The following is a description of a gene set: from publication Chen Y, Wang X (PMID 31504780) Genes predicted to be targets of miRBase v22 microRNA hsa-miR-526b-3p in miRDB v6.0 with MirTarget v4 prediction scores > 80 (high confidence targets). Human Gene Set: MIR526B_3P studied in species Homo sapiens, and this is the list of marker genes: PRR14L, CLIP4, OSTM1, LRPAP1, ZNF280B, ZNF264, RORC, FBXL3 (NCBI Gene Id 26224), PKD2, PLEKHA3, ARHGEF3, USP32, VSX1, BRMS1L, PCDHA12, MOSMO, CALD1, CCDC71L (coiled-coil domain containing 71 like), PTHLH, USP3, ZNFX1, DENND10, NIPA1, TMEM167A, KLF11 (NCBI Gene Id 8462), RRM2, ZBTB9, PPP1R15B, RLIM, ERAP1, HBP1, BAHD1, ENTPD4, RAB5B, RBBP7, DNAJC27, ETV1, SSX2IP, SRCIN1, RCCD1, PTPN4, FGD4, SLC45A4, BTBD10, BCL11B, CEP170, MKNK2, EPHA4, RAB22A, ARMC8, ZBTB20, KLHL28, PCDHA2, PURB, MKRN1, MAGI3, RAB8B, APP (NCBI Gene Id 351), ULK1, SLC24A2, PTPDC1, GOSR1, TMEM127, ANKRD52, RASGRF2, ZNF25, OTUD4, SMOC1, STXBP5, FAM13C, SPTY2D1, SMOC2, KIAA0513, RGMB, EGLN3, SLC40A1, DDX5 (DEAD-box helicase 5), TBC1D20, TET3, MASTL, LASP1, USP6, ARHGEF11, MMP2, TGFBR2, FSD1L, REV3L, CDC23, DNAJC16, FBXL5, KIF3B, IQSEC2, CORO2B, LDLRAP1, TRDN, NPAS3, STRIP2, AGFG1, BRWD1, PFKP, SOS1, ZNF148, EREG, SUCO, VLDLR, ZBTB7A, U2SURP, ANKRD13C, ZFYVE9, SUSD6, TRIM36, HIF1A, SOX4, TNFAIP1, AHNAK (AHNAK nucleoprotein), MTMR3, TNFRSF21, MYT1L, PLXDC2, CHD5, NAGK, ZNF236, ANKIB1, TFAM, RAP2C, KLHL2, TRAPPC14, SLC16A6, KIF23, ORMDL3, NR2C2, CNOT7, NEDD4L, CMTR2, GUCY1A1, SFMBT1, UNC80, TRIM37, ENTREP2, CRY2, PCDHA4, KLHL15, MINK1, PCDHA8, EZH1, PCDHA7, SLC4A8, EMSY, CD69, USP46, SRGAP1, AMER2, BEST3, CXCL6, ZHX2, RRAGD, PCDHA1, PCDHA6, ARHGEF18, E2F5 (NCBI Gene Id 1875), UBE2Q2, MYO5B, RAB11FIP1, FYCO1, PAPOLB, NIN, PCDHA10, ITGB8, NDEL1, FAM13A, USP24 (ubiquitin specific peptidase 24), LYST, RPS6KA6 (NCBI Gene Id 27330), LPGAT1, PTPN21, CCNG2, EFCAB14, PRR15, MAPRE3, PIK3R1 (NCBI Gene Id 5295), TENM1, SORL1, SLAIN2, WDR37, C2CD2, SAR1B, EGR2, TMX3, CEP120, DERL2, ABCA1, PSG3, KIAA1191, ARHGAP1, TRIP11, TPRG1L, KLF9, ST6GALNAC6, DUSP8, SNX16, ANKRD17, BCL2L11, PFKFB3, CHP2, EPS15L1, ELK4, LIMA1, ARHGAP12, CPEB3, P2RX4, GNPDA2, PTGDR, SMAD5, CREB5, GPR137B, FBXO31, NKIRAS1, FASTK, NTN4, RETREG3, ITPRIPL2, ARHGAP26, BHLHE41, DUSP2, SSH1, NPAT, KCNJ10, UEVLD, TMBIM6, PCDHA13, SRPK2, SACS, SLC49A4, ARHGEF10 (NCBI Gene Id 9639), ZNF800, ANKRD29, RPS6KA4, LRP8, IL6ST, NR2C1, CHRM2, DCBLD2, ARHGEF28, B3GALT2, TNKS1BP1, NHLRC3, GXYLT1, AAK1, CERCAM, PPP1R3B, SNTB2, TRPV6, KMT2B, TAOK3, SALL3, RGMA, RAB12, TMEM138, SLC16A9, FCHO2, OXR1, ATG16L1, CTSK, CC2D1A, SH3PXD2A, UBXN2A, MFSD8, CSRNP3, ANKRD33B, PGM2L1, OLFM3, FNBP1L, ANKFY1, JPT1, PHIP, ISM2, AFG1L, WFS1, RAPGEFL1, TSG101, DCUN1D1, SAMD8 (sterile alpha motif domain containing 8), NIBAN1, NAPEPLD, FAT4, HLF, UXS1, PRCP, TRIP10, SOCS6, TP73, ARID4A, DENND5B, VANGL1, CDC37L1, STK11, LAMA3, ZFYVE26, REST, ATAD2, PRDM6, HAUS8, MYLIP, THRA, ZBTB18, CYBRD1, ABI1, FGD5, PDLIM5, BBX, MAPK4, ATG2B, NTNG1, SLITRK3, MEX3D, LIMK1, ZNF597, KPNA2, NFAT5, STK17B, PAPOLA, RUNX3, MAP3K14, AGFG2, USP28 (NCBI Gene Id 57646), CD274, TM2D2, RB1CC1, NCOA3, ITGA4, SALL1, DPYSL2, PCDHAC1, DNAJB9, L3MBTL3, PAK5, MAPK1, IL1RAP, BNIP2, PCDHA5, ATXN1L, RORA, OSM, HPS5, FAM210A, ABL2, ANKH, RHOC, HAS2, PDGFRA, PCDHA3, PXK, SLC17A7, NRIP3, SERP1, TMEM168, FEM1C, CEP97, BICC1, MIDN, HS3ST5, ZBTB4, ZNF827, SERTAD2, ADAM9 (NCBI Gene Id 8754), HTR2A, FAT2, URI1, SEMA4B, CMPK1, SEMA7A, AKTIP, SLC33A1, TRIM3, PCDH15, NUP35, ELK3, EPHA7, GPR63, SEPTIN2, GPR137C, PDCD1LG2, ZNF652, CFL2, SMAD4, TET1, HECTD2, ZFAND4, TANC1, DPYSL5, TMEM265, MCF2L, YOD1, AGO1, ARAP2, TMEM100, MMP24, TXNIP, ROCK2, KATNAL1, XRN1, BTBD7, TAFA1, RACGAP1, APCDD1, MAP3K2 (mitogen-activated protein kinase kinase kinase 2), PITPNA, TIAM1, CRYBG3, REPS2, MED12L, DRD1, SQSTM1, LYPD6, ZNF704, IRF1 (NCBI Gene Id 96501), GLIS3, RNF128, UBE3C, ANO6, USP31, SGMS1, PANX2, AKAP11, DAB2, UNKL, PCDHA11, FAM199X, ZNF512B, FLT1, PGBD5, ZDHHC1 (NCBI Gene Id 748), CENPQ, UNK, CLOCK (clock circadian regulator), GPR6, GPATCH2, BICD2, ZFPM2, STYX, AGTPBP1, LRIG1, FOXJ3, NPAS2, ZBTB41, MYNN, ZNF367, NEUROG2, LHX6, EIF4A2, REEP3, TNKS2, ST3GAL1, MAP10, FZD3, DNAL1, AP2B1, SPRED1, SERF1A, TBC1D9, MARCHF8, KLF12, SCN1A, KAT2B, FJX1, KCNB1, PCDHAC2, RNASEH2B, ARID4B, ENPP5, STK38, WDFY3, PLXNA1, RPS6KA5, CNRIP1, NANOS1, IGSF10, MFAP3L, GAB1, MCL1, KMT2A, RGL1, RBL2, SIKE1, SYTL4, OCRL, MFN2, NACC2, CCND1, PKD1, PLCB1, TMEM64, TAOK1, PLAGL2, FBXO21, PTPRD, ZBTB33, RNF6, ABHD2 (NCBI Gene Id 654057), IRF9, RASD1 (NCBI Gene Id 63428), SLC46A3, CROT, KCNK10, RASL11B, CNOT4, ZXDA, MAP3K9, RSRP1, FAM117B, GOLGA1, ABCG4, C14orf28, BTG3, PBX3, MAP3K8, LRCH1, PDE3B, NABP1, TBC1D8B, LRRC55, SH3BP5, LAPTM4A, CMKLR1, DDHD1, PHC3, ERC1, AKAP13, NPLOC4, EIF5A2, SLMAP, FAM219B (family with sequence similarity 219 member B), ATL3, LCOR, PARD6B, HYCC2, PPP1R21, HSPA8, SESN3, F3, GNB5, SAMD12, RUFY2, ANKRD50, ACSL4, TAGAP, ZC3H12C, PRRG1, GABBR2, VASH2, HEG1, WDFY2, KMT5B, RETREG2, SPOPL, PSD, CNOT6L, WNK3, CTSA, ZBTB21, ADARB1, C2orf69, SNX8, SLC22A23, OSR1, CDKN1A, STAT3, PTPN3, KIF26B, DYNC1LI2, CAPRIN2 (caprin family member 2), BNC2, E2F1, NBEA, UTP23, FOXK2 (NCBI Gene Id 84213), PEX5L, ZBTB8A, RAB11FIP5, ZSCAN20, ZFP91, CREB1, NCKAP5, FBXO48, TOPORS, NAA30, SERF1B, FNDC3B, FRMD6, CAMTA1, ZDHHC9, GRAMD1A, ATP12A, PPP3R1, GNS, RAPH1, CAPN15, LDLR, EPHA5, LMO3, SSH2, S1PR1 (sphingosine-1-phosphate receptor 1), BMPR2, EEIG1, TGM2, LZIC, FRS2 (NCBI Gene Id 10818), DOCK4, JAK1, PPP6C